The following is a description of a gene set: Mouse Gene Set: GOCC_SHELTERIN_COMPLEX species: Mus musculus A nuclear telomere cap complex that is formed by the association of telomeric ssDNA- and dsDNA-binding proteins with telomeric DNA, and is involved in telomere protection and recruitment of telomerase. The complex is known to contain TERF1, TERF2, POT1, RAP1, TINF2 and ACD in mammalian cells, and Pot1, Tpz1, Rap1, Rif1, Rif2 and Taz1 in Saccharomyces. Taz1 and Rap1 (or their mammalian equivalents) form a dsDNA-binding subcomplex, Pot1 and Tpz1 form an ssDNA-binding subcomplex, and the two subcomplexes are bridged by Poz1, which acts as an effector molecule along with Ccq1., and this is the list of marker genes: Acd, Terf2, Pot1a, Tinf2, Terf1, Pot1b, Terf2ip, Terb1